The following is a description of a gene set: Mouse Gene Set: MIR_12189_3P studied in species Mus musculus from publication Chen Y, Wang X (PMID 31504780) Genes predicted to be targets of miRBase v22 microRNA mmu_miR_12189_3p in miRDB v6.0 with MirTarget v4 prediction scores > 80 (high confidence targets)., and this is the list of marker genes: Edil3, Cept1, Ankrd45 (ankyrin repeat domain 45), A1cf, Rab11fip4 (NCBI Gene Id 319892), Prdx3, Tsc1, Trim39, Taf9b, Serpina3n, Tnrc6c, Ube2r2, Ccl22, Cpsf6 (cleavage and polyadenylation specific factor 6), Socs7, Poldip2, Apoo, Cobl (cordon-bleu WH2 repeat), Csf1, Dhx40, Rab30, Slc38a2, Gpc6, Mmp11, Ermn, Pecam1, Ube2l6, Tmem181a, Il6ra, Sorcs3, Tnrc6a, Fat4, Zfp704, Zfp362 (NCBI Gene Id 230761), Angel1, Igf1, Fbn2, Ntng1, Yipf2, Tmem184b (transmembrane protein 184b), Myrf, Ptbp3, Rskr, Idh3a